Given this list of marker genes FGF9 (fibroblast growth factor 9), RESP18, SLC4A3, SLC5A4, PAM16, NIPBL, MGAT4C, MRPL42, ZNRD2, PRSS37, TRPM5, PTOV1, CYBB, CPA1, SLC15A1, MAPK13, ATP5F1E, ZNF566, IGKC (immunoglobulin kappa constant), HNF1B (HNF1 homeobox B), DCTPP1, EMD, BANP, RPSA, YEATS4, TOR2A, OR6A2, ME1, PFN3, STUB1, PNKD, NIT1, MYBPH, PSMD7, ANGPTL3, SORBS1, C8G, DPYD, NDUFAF1, SLC46A2, TTPA, PSMB9, ENTR1 (NCBI Gene Id 10807), TRA2B, RPS3A, ABAT, MMS19, SUPT20H, NUCB2, DUSP10, IFNAR2, CLN6, CHCHD10, WFDC5, STEAP1, BNIP2, VRK2, ROM1, JPH2, KIF9, PRSS12, C11orf68, ENDOG, NMBR, NAGK, DACH1, RRP9, PLAAT3, GAST, TNFRSF1B, APOE, MRPL30, CCND2, BTF3L4 (basic transcription factor 3 like 4), MED28, PDZK1IP1, HVCN1 (hydrogen voltage gated channel 1), SVBP, DLD, S100G, ELMO2, MRPL28, ST8SIA2, ECH1, PRRC1, C2orf49, TDRD7, WDR43, N4BP3, PPIL2, SMPD2 (NCBI Gene Id 6610), ATCAY, FAM193B, NUDT16, DUSP15, UNC13B, SFRP1, ALDH3B1, GPR137B, RPL22, TSEN34, LMO7, B3GAT3, TRIM6, SNHG8 (NCBI Gene Id 100093630), RGL2, EDN2, JMY, DGCR6, ACOT12, ROBO4, PBX3, CENPA, POLG, ZMIZ1, PRKAB1, MEPCE (NCBI Gene Id 56257), HES1, RB1CC1, TMEM214, GPR45, PITPNB, SCN3A, RASAL3, C7orf25, CLDN3, RALBP1, GTF3A, RAE1, CHCHD7 (NCBI Gene Id 79145), ZC3H3, PIP5KL1, ZNF281, ANXA10, ZMPSTE24, ORMDL3, AGTRAP, STBD1, STK16, MMADHC, TAFA5, SLX9, LRP4 (NCBI Gene Id 4038), RANBP17, SKP2, TP53BP1, ENKD1, PTCD2, MYT1L, P2RY12, CANT1, ACSF3, MRPS15, RAG1 (NCBI Gene Id 5896), DUSP18, DNASE1, MB, DYNLT4, AKR7A2, JPH1, MBD3, TXNRD3, SLC8A1, DDX18, CYP2S1, OSTF1, ITGA4, AP3B2, COPS7B, STX7, UBALD2, ZBTB17, ZNF354B, REG1A, CDIP1, KXD1, EIF2S1, APIP, MRPL49, COCH, CCDC6, MDH1, SLC6A14, IL9R, IL17RA, CNTN4, MTAP, CDK4, RPL39, MOG, TGM2, NUP133, B9D2, FDFT1, TRIM26, KLHL9, ZNF276, SARS1, FOXB1 (NCBI Gene Id 27023), EHBP1L1, here is a description of the gene set: Genes up-regulated in comparison of dendritic cells (DC) stimulated with LPS (TLR4 agonist) at 0.5 h versus DC cells stimulated with Pam3Csk4 (TLR1/2 agonist) at 0.5 h. species: Homo sapiens Human Gene Set: GSE17721_LPS_VS_PAM3CSK4_0.5H_BMDC_UP from publication Amit I, Garber M, Chevrier N, Leite AP, Donner Y, Eisenhaure T, Guttman M, Grenier JK, Li W, Zuk O, Schubert LA, Birditt B, Shay T, Goren A, Zhang X, Smith Z, Deering R, McDonald RC, Cabili M, Bernstein BE, Rinn JL, Meissner A, Root DE, Hacohen N, Regev A (PMID 19729616) mouse primary BMDCs were stimulated with tlr ligands and gene expression changes were profiled on Affymetrix arrays